The following is a description of a gene set: studied in species Homo sapiens Human Gene Set: GOBP_NEGATIVE_REGULATION_OF_MEIOTIC_NUCLEAR_DIVISION Any process that stops, prevents, or reduces the frequency, rate or extent of meiosis., and this is the list of marker genes: KNL1, RPS6KA2, ZWINT, TRIP13, DMRT1, LIF, HORMAD1, RAD1, NANOS2, FBXO43, FBXO5